The following is a description of a gene set: A SWI/SNF-type complex that contains 8 to 14 proteins, including both conserved (core) and nonconserved components; contains the ATPase product of the Drosophila brm (brahma) or mammalian SMARCA2/BAF190B/BRM gene, or an ortholog thereof. Mouse Gene Set: GOCC_BRAHMA_COMPLEX species: Mus musculus, and this is the list of marker genes: Smarcb1, Arid1a, Actl6b, Smarcc1, Smarcd1 (NCBI Gene Id 83797), Smarcd3, Actl6a, Smarcc2, Arid1b, Arid2 (AT-rich interaction domain 2), Actb, Smarce1, Dpf3, Smarca2, Smarcd2